Given this list of marker genes CNBD2, ACVR1, CHTF8, DHX34, ARID1B (AT-rich interaction domain 1B), GRIK5, DSCAML1, PAPPA, RIGI, ARPP21 (cAMP regulated phosphoprotein 21), DCLK1, CEP57, POLR1H, SLC4A10, CASTOR3P, ARHGEF11, EZHIP, ZSCAN32, DGKK, NETO2, SPRY4, USO1, DMRT2, ARK2N, NET1 (neuroepithelial cell transforming 1), UBE2D2, CEBPG, ZNHIT6, PEX11A, CDADC1, YTHDF1, CYTH3, DNTTIP2, DSG1, KDELR3, TRAT1, TIPARP, WARS1, SF3A3, CLCA2, SLC30A5, BLID, MRPL35, PLCG2, here is a description of the gene set: studied in species Homo sapiens from publication Chen Y, Wang X (PMID 31504780) Genes predicted to be targets of miRBase v22 microRNA hsa-miR-193a-5p in miRDB v6.0 with MirTarget v4 prediction scores > 80 (high confidence targets). Human Gene Set: MIR193A_5P